The following is a description of a gene set: part of: NOTCH3 Activation and Transmission of Signal to the Nucleus Reactome Pathway: Noncanonical activation of NOTCH3 This event has been computationally inferred from an event that has been demonstrated in another species.<p>The inference is based on the homology mapping from PANTHER. Briefly, reactions for which all involved PhysicalEntities (in input, output and catalyst) have a mapped orthologue/paralogue (for complexes at least 75% of components must have a mapping) are inferred to the other species. electronically inferred by orthology from the curated human pathway species: Mus musculus, and this is the list of marker genes: Psen1, Notch3, Psenen